The following is a description of a gene set: species: Homo sapiens Human Gene Set: MIR16_1_3P Genes predicted to be targets of miRBase v22 microRNA hsa-miR-16-1-3p in miRDB v6.0 with MirTarget v4 prediction scores > 80 (high confidence targets). from publication Chen Y, Wang X (PMID 31504780), and this is the list of marker genes: CNST, EHBP1, KIAA0232, KIF3A, EIF5B, TMEM68, MOGAT2, CCDC7, FYN (NCBI Gene Id 2534), TEAD1, PNRC1, C11orf54, AZI2, MFAP4, GNG12, CLDN23 (NCBI Gene Id 137075), ABCA1, JAG1, CLDND1, HYCC2, USP6, CNTN1, BRIP1, TM9SF2, AKR1D1, PDE3B, CLVS1 (clavesin 1), UBE2G1, FAT4, BRPF1, MBTD1, C1orf185, UBR3, DPP4, PSMD10, RIN2, RAB23, TOPORS, DENND6A, STARD8, ANO1, ROCK1, IRAK1BP1, SLITRK4, SPEN, GUCY1A2, ZSCAN26 (NCBI Gene Id 7741), BRINP3, SEMA6D, AMN1, C1GALT1C1, REL, TMEM67, NPY2R, PNMA2, CREB1, HS6ST3, RNF41, COCH, KTN1, TTC13, UGT8, HMGCS1, SRPK1, PCLO, FBN2, ARPC5, SEPTIN2, UBE2E3, KMT2E, C8B, HAT1, ENPP6, STK17B, YY1, CPSF2, SLC12A2, GFRA2, MATR3, AIMP1, CREB5, ZBTB21, CEP135, SLC10A7, LLGL1, CISD1, PACRGL, BNC2, SCAF4, CAPS2, LOX, ABCA13, PRR16, ATXN10, ACSM1, LSM8, B3GALNT1, ANKRD12, INTS8, BEX3, ZHX1, PDZRN4, ZFX, RNF6, GPR182, NUP98, FUT8, STAU1, FERMT1, SLC12A6, PCDH7, TDRD3, ZNF736, ANP32E, HSPA5, TTC17, TLCD4-RWDD3, FAN1, MTRR, P2RY14, KANSL1L, PIK3C2A, MCTP1, ATP2A2, C19orf73, NF1, SUCLA2, GPALPP1, KLF5, KLHL24, SEC14L1, CCDC112, DOCK3, PANK3, PRRC1, DICER1, STX7, CCNE2, FOXO1, TBC1D32, COL4A3 (collagen type IV alpha 3 chain), FAM110B, ABCA8, ZDHHC17 (NCBI Gene Id 23390), MOB1B, SCARB2, TTC14, CPNE8, PHC3, TGFBR2, MMGT1, SPOCK1, UNC80, RRM2B, SS18, NPAP1, WNK3, MARCKS, TMTC2 (transmembrane O-mannosyltransferase targeting cadherins 2), VCPKMT, POU3F3 (POU class 3 homeobox 3), ZC2HC1A (NCBI Gene Id 51101), SLC31A2, GRIA4 (glutamate ionotropic receptor AMPA type subunit 4), TFAP4, SRI, MIX23, SNX29, TMEM237, RAD18, STEAP2, CAB39, ALDH1L2, KPNA1, TOX4, SCN8A, NOD1, LIN54, ZDHHC21, ZCCHC2, TENT4B, CC2D2B, PHYKPL, EBF1, IL26, HLF, DLG5, PARP8